The following is a description of a gene set: Diseases of DNA repair Human Gene Set: REACTOME_DISEASES_OF_DNA_REPAIR studied in species Homo sapiens, and this is the list of marker genes: ATM, NEIL3, PALB2, ATRIP, RPA3, NBN, MSH6, BRIP1 (NCBI Gene Id 83991), BLM, RMI1, RPA1, BRCA1 (BRCA1 DNA repair associated), OGG1, TOP3A, RAD51AP1, RAD50, NTHL1, RBBP8, RPA2, ATR, RHNO1, EXO1, BRCA2, XRCC2, RAD51D, TOPBP1, MSH2, DNA2 (DNA replication helicase/nuclease 2), RFC4, KAT5, WRN, NEIL1, MRE11, RAD51C, RFC3, SEM1, RAD9A, HUS1, RMI2, MLH1, RAD9B, RAD1, BARD1, RFC2, RAD17, MSH3, MUTYH, RAD51, RFC5, RAD51B, PMS2